Given this list of marker genes PAOX, SMOX, SAT1, here is a description of the gene set: part of: Metabolism of polyamines Reactome Pathway: Interconversion of polyamines studied in species Homo sapiens The reactions catalyzed by aminopropyl-transferases annotated above are generally irreversible. But spermine and spermidine can be recycled respectively into spermidine and putrescine. These events require the formation of N-acetylated intermediates, N1-acetylspermine and N1-acetylspermidine catalyzed by a cytosolic acetyl-CoA:spermidine/spermine N1-acetyl-tranferase (SSAT) enzyme.<br>Subsequently, polyamine-oxidase (PAO), a FAD enzyme present in the peroxysomes, yields a polyamine with release of an aldehyde (3-acetamindopropanal) and H2O2.<br>In addition, SMOX, a FAD-dependent, polyamine oxidase (PAOh1/SMO) that can efficiently use spermine as a substrate and is involved in interconversion reactions.